The following is a description of a gene set: A sensation of tightness in the neck when attempting to move it, especially after a period of inactivity. Neck stiffness often involves soreness and difficulty moving the neck, especially when trying to turn the head to the side. Stiff neck studied in species Homo sapiens Human Gene Set: HP_STIFF_NECK, and this is the list of marker genes: NEK9, NDE1, LMNA, NDUFS3, DKK1, COL2A1 (collagen type II alpha 1 chain)